The following is a description of a gene set: species: Homo sapiens Human Gene Set: HP_DUPLICATION_OF_THE_DISTAL_PHALANX_OF_HAND Duplication of the distal phalanx of hand This term applies if one or more of the distal phalanges of the hand are either partially duplicated, depending on severity leading to a broad or bifid appearance of the phalanges, or completely duplicated., and this is the list of marker genes: WNT5A, LEMD3, ROR2, DVL1, FGFR2, TWIST1, PPP2R3C, CANT1 (calcium activated nucleotidase 1), PAH, KIF7, GDF5, BMPR1B